Given this list of marker genes MAPK1, FRS2, FAM53A, FGFR3, NELFA, NELFE, NICOL1, NELFB, TMEM129 (transmembrane protein 129, E3 ubiquitin ligase), MAPK3, POLN, CLTCL1, SOS1, H3-3A, NAT8L, TACC3, BCS1L, LETM1, GRB2, FGF2, NELFCD, NSD2, CKAP5, CBL (Cbl proto-oncogene), MIR943, SLBP, SCARNA22, PIK3R1, UBE2J2, GAB1, PLCG1, ERI1, here is a description of the gene set: 4p16.3 copy number variation Human Gene Set: WP_4P163_COPY_NUMBER_VARIATION species: Homo sapiens